The following is a description of a gene set: The main sulfur amino acids are methionine, cysteine, homocysteine and taurine. Of these, the first two are proteinogenic.<br><br>This group of reactions contains all processes that 1) break down sulfur amino acids, 2) interconvert between them, and 3) synthesize them from solved sulfide which comes from sulfate assimilation and reduction. Only plants and microorganisms employ all processes. Humans cannot de novo synthesize any sulfur amino acid, nor convert cysteine to methionine (Brosnan & Brosnan, 2006). Reactome Pathway: Sulfur amino acid metabolism species: Homo sapiens part of: Metabolism of amino acids and derivatives, and this is the list of marker genes: ETHE1, MTAP, APIP, MRI1, CBS (cystathionine beta-synthase), TSTD1, BHMT2, MPST, CDO1, GOT2, ENOPH1, SUOX, ADO, GADL1, SQOR, SLC25A10, GOT1, MAT1A, MTRR, TXN2, FMO1, MTR, AHCY, TST, BHMT, CTH, CSAD (cysteine sulfinic acid decarboxylase), ADI1